The following is a description of a gene set: species: Homo sapiens Human Gene Set: GOBP_DEFENSE_RESPONSE_TO_SYMBIONT Reactions triggered in response to the presence of a symbiont that act to protect or prevent damage to the host., and this is the list of marker genes: TAX1BP1, CD274, NLRX1, TRAF2, GRN, MIF, WFDC10A, DAO, DMBT1, C3, CCDC92, DEFB103A, PRDM1 (PR/SET domain 1), DAB2IP, TRIM43B, SRPK2, BPIFB3, RNASE3, UFD1, TRIM32 (NCBI Gene Id 3971), TNFAIP8L2, TRIM49C, PRKDC, LTF, REG1B, PRSS3, RNF166, PIK3R6, SYK, PSTPIP1, PTPN11, RSAD2, TRIM26, RAET1E, DHX16, RPL13A, DDX60, DEFB118, SIGLEC10, XIAP, TMEFF1, CCL28, APPL2, TRIM68, LRRC19, HSP90AA1 (NCBI Gene Id 89272), CARD8, IFIT3, KIR2DL4, MICA, TUBB, MNDA, CYP27B1, JAK2, KLRG1, IFNA4, CLPB, DHX58 (NCBI Gene Id 79132), SUSD4, IFNA1, IRAK1, CLNK, UMOD, CYBA, VAMP4, PARP9, CCL5, DDX21, NCR1, APPL1, CFD, USP14, CCL17, NFKBIA, HSPA1A, PYDC5, DAPK3, CFB, CD84, GCH1, CCL16, ZDHHC1, ENDOD1, PAK1, MMP12, CNPY3, DHX9, TASL, GBP3, SMIM30, HRG, HDAC6, TRDV2, CXCL6, S100A14, WRNIP1, TARM1, CD74 (NCBI Gene Id 972), CLEC4E, GP2, MSRB1, HAMP, USP38 (ubiquitin specific peptidase 38), KRT16, IFNA2, FGB, C7, PCYOX1L, TLR4, KLRC4, MMP7, EP300, ACTG1, APOL1, LY86, RNF125 (NCBI Gene Id 54941), UBE2L6, PLPP6, IRF5, KIF5B, DEFA3, MAPK8, DEFB107A, SKP2, DEFA1B, ITGAM, IFI35, MRC1, TRIM43, IL12RB1, POLR3C, CAMP, GDI1, CALCOCO2, DEFB125, ELANE, EPRS1, PPP2R3C, TRAF3IP3, KLK7, DEFB128, TRIM63, CEACAM1, S100A7, ZDHHC11B, F2 (coagulation factor II), PLA2G5, SLAMF1, RELB, KLRC4-KLRK1, H2BC12, DEFB134 (defensin beta 134), PIK3CB, TRIM38, SETD2, GZMM, IFNA10, RNF115, CCL25, IRAK2, HERC5, CCL2, CX3CR1, PADI4, PYHIN1, RFPL2, SAMHD1, BPIFB1, CPTP, IKBKG, C1QB (complement C1q B chain), IFNA7, IKBKE, H2BC11, ARHGEF2, SEC14L1, HAVCR2, CCDC134, TRIM15, RIPK2, CD180, C6, EREG, RDUR, PUM2, CCL23, MUL1, HSP90B1, ANKHD1, DEFB1, AP3B1, NECTIN2, RIGI, HDAC4, MARCHF5, STAT1, TRDV3, IKBKB, TRIM11, ATAD3A, LY96, PTX3 (pentraxin 3), ZNF683, PRTN3, IFNA14, CCL27, IFIT1, DHX33, CHUK, SERINC3, PLD4, LYST, GBP1, YTHDF2 (YTH N6-methyladenosine RNA binding protein F2), POLR3B, TRIM48, GATA6, SERPINB9, POLR3F, LACC1, APOBEC3H, YWHAE, GZMB, ESR1, ELP6, N4BP3, RNF170, MPEG1, SRC, MIR520E, SLAMF7, LCN2, IL34, LRRC14, MIR19A, RARRES2, CCL3L3, KLRC3, CAMK2A, PTPRS, BIRC2, NLRP10, TRAFD1, BRCC3 (BRCA1/BRCA2-containing complex subunit 3), PTPN2, LYAR, XRCC6, VIP, IL36B, TRGV2, IL1RL2, CLDN2, TRIM59, C9, BCL3, LRP8, SPINK5, TRIM39, MX1, TRIM77, C8B, TREML1, FPR2, CREBBP (NCBI Gene Id 1387), CIITA, APOBEC3D, OAS1, EDN1, RAB20, GPER1, CCL18, IGHG3, DEFB113, ARL8B, NMI, PTPN6, TOMM70, RB1CC1, CD47, TRIM61, TRAF4 (TNF receptor associated factor 4), AP1G1, NFKBIZ, MX2, CX3CL1, PRKRA (protein activator of interferon induced protein kinase EIF2AK2), OAS3, C4BPB, DCST1, ZDHHC11, LAG3, TARBP2, HCFC2, CLU, LILRA4, TNIP3 (TNFAIP3 interacting protein 3), ZG16, OTULIN, IFNAR1, KIR3DL1, ITCH, CSF1, NR1H2, MORC3, TLR3, HLA-G, MIR149, PDE12, TRIM64C, DEFB106A, IFNA16 (NCBI Gene Id 3449), DNAJA3, IFNK, RPS6KA3, HK1, SLC26A6, MALT1, CR1, CCL14, MAP2K6, C5, VPS26B, RFPL4AL1, NQO1, P2RX7, AKT1, PHB2, LYN, IL33, HLA-E, TAB1, TRIM73, CD209, TMEM45B, ZDHHC18, SH2D1B, ZNRF4, ATG5, RBM14, KCNJ8, UAP1, IL27, MED1, TNFRSF14, NLRP6, POLR3K, CLEC2A, TRIM72, IGHG1, IL12A, HPX, CFP, CCL15, TRIM17, KIR2DS2, CD1D, PPT1, TRIM65, PIK3CD, STMP1, NEK7, IL23R, MIR146A, KYNU, TRIM54, INAVA, C4A, SEMG2, AIF1, ADAR, LYPLAL1, CACTIN, KRT6A, RFPL3, TRIM74, KLK5, IL1RAP, NCF1, ZYX, SAMD9, CLEC4D, HSPD1, PHB1, BPIFA1, RPSA, TMEM43, UBL7, LSM14A, NKG7, F12, CASP8, SHFL, IFNL3, CDC42, CFHR2, RNASE7, MYD88, PYDC2, IRF8 (NCBI Gene Id 3394), IFNGR2, RAB7B, USP44, CORO1A, IL17F, USP29, LY6E, IL23A, CFHR5, DEFB116, SIRT2, A2M, SFN, STAT5A, B2M, MATR3, USP27X, IGHA1, CCL4L2, WFDC13, COLEC10, IFIH1, S100A8, NUB1, TYROBP, FBXL2, CNOT7, CD36, YTHDF3, IL10RB, TMEM33, CFHR1, PTPN1, IGHD (immunoglobulin heavy constant delta), CXCL10, INPP5D, GSDMB, HTN1, GPR146, PPP6C (protein phosphatase 6 catalytic subunit), TNFAIP3, SHMT2, DDX3X, DUS2, IFNA8 (NCBI Gene Id 95818), TRIM51G, NINJ1, ATP1B1 (ATPase Na+/K+ transporting subunit beta 1), CRP, CYLD, CCL4, ULBP3, SMPD1, IRAK3, CD244, TRIM35, HEXIM1, TRIM13, IL17A, RNASET2, TRIM6, PIK3CG, DDX39A, ZNF697, TRIML1, TREML4, NR1H4, MIR21, LETMD1, TRIM31, MIR210, TRIM55, SERINC5 (serine incorporator 5), NLRP1 (NCBI Gene Id 82286), PPP1R14B, SPI1, PF4, RNF19B, CYBB, PARP14, GBP4 (NCBI Gene Id 115361), SNX3, HMGB1, IFNL2, NLRC4, LRRC15, EVPL, OTOP1, ULBP2, SYNCRIP, IRF3, TOLLIP, ZBP1, PRKD1, CCL21, GSDMD, TREM1, USP18, HCST, H2BC6, DEFB4A, ATAT1, IRF4, NMBR, OPTN, SEMG1, CLEC4M, TICAM2, COLEC11, WFDC9, C4B (NCBI Gene Id 721), TRIM23, ANXA1, POLR3G, IGKV3-20, TICAM1, ERAP1 (NCBI Gene Id 51752), GFI1, SP100, CCL1 (NCBI Gene Id 6346), CD300LF, ACTR2, AKIRIN2, KAT5, ANG, TRIML2, PYDC1, TLR1, VIM, YWHAZ, PLA2G2F, CXCL13, RAB43, EIF2AK2, GALP, MID2, H2BC4, PGLYRP4, KLRC1, CDC42EP2, RBM47, DDX41, NCK1, APOBEC3F, JAK3, FCGR2B, ADGRB1, TRIM21, CCL20, CD300A, CD300H, TRIM52, NEURL3, UNC13D, CRTAM, TRIM40, CCL8, CHID1, RNASE4, IFNA17, SCNN1B, LILRA2, SEC61A1, G3BP2, SDHAF4, ZCCHC3, TIFAB, CLEC5A, BTK, C4BPA, TIRAP (TIR domain containing adaptor protein), CST9L, CR2, AQP4, MIR758, ADAM15, AURKB, PSPC1, CALM1, IL21, LGALS3, PUM1, DAPK1, POLR3E, TLR5, NLRC5, SLC15A4, KRT1, ATG14, KLRF1, NPPB, NCR3, SNCA, CXCL14, HLA-DPA1, MST1R, MASP1, DEFB126, CLEC7A, TLR2, SH2D1A, DCD, SIN3A, UBE2K, HMGN2, NMB, SFPQ, TRIM25 (NCBI Gene Id 7706), CXCL11, NLRP9, USP50, FCN3, RFPL4B, GPR108, NLRP2, PCBP2, CCL3, GPS2, DEFB115, SCARA3, APOBEC3C, MARCO, CLEC4C, DEFB108A, METTL3, TLR8, TRIM64B, CEBPG, RNF39 (ring finger protein 39), POLR3H, TIFA, NRROS, PAK2, PLA2G6, PQBP1, IL36A, TRIM8, LAMP2, DHX15, MIRLET7B, DEFB107B, MFHAS1, MAP3K5, STX4, USP17L2, IRGM, APOBEC3B, USP20, STXBP3, RAF1, NFKBIL1 (NFKB inhibitor like 1), FADD, KCNK6, IL17RA, ADAM8, TMEM126A, SLC19A1, DTX3L, LAMP1, JCHAIN, TREM2, WFDC10B, CAV1, SPON2, DEFB108B, CRCP, PGLYRP1, FGR, MIR4691, ATG9A, SERPINB4, CCL22, CDC42EP4, FLOT1, C1QBP, USP15, NPLOC4, STING1, TMEM106A, MCOLN2, SFTPD, ZNFX1, TRIM34, VSIG4, TUBB4B, NLRP2B, SPIRE1, TRIM49D1, ZDHHC3, TKFC, NOD2, TYK2, NOS2, BPIFC, SARM1, LEAP2 (NCBI Gene Id 116842), SLC46A2, SPSB3 (splA/ryanodine receptor domain and SOCS box containing 3), CD96, CALHM6, RAET1G, APP, AIM2, CSNK1A1, WFDC12, OASL, PLSCR1, CXCL3, TRIM49B, HSPA8, IFNE (interferon epsilon), PRSS2, FOSL1, DEFB127, TRIM60, LYZ, TRIM22, APOE, PPARG, ABHD17A, GBP2, EPG5, RNF185 (ring finger protein 185), POLR3D, ECSIT, IFNW1, TRDV1, RFTN1, TBKBP1, NEDD4, NCF2, SPAG11B, WNT5A, SLC15A2, TRIM49D2 (NCBI Gene Id 729384), CD177, GRB2, CXCL1, MMP3, C1S, TOR2A, CRK, SMPDL3B, PI3, CXCL8, DEFB135, WASHC4, HLA-F, DEFB132, TRAF3, IFITM1, TRGV5, HMGB3, XCL2, VAMP3, GBP5, TRIM27, NR1D1, TNIP1, TRIM10, GAPDH, LGR4, CRISP3, FAM3A, MAVS, PYCARD, CD2 (CD2 molecule), FLNB, NOD1, IRF7, CXCL9, CD300E, APOBEC3G, H2BC7, TXK, ARG2, ANKRD17, UBE2W, CD6, AKAP1, PLEKHM2, CXCL16, PRDX1 (peroxiredoxin 1), BPI, CCL19, OTUD4, PIM1, IFNGR1, VAMP2, H2BC10, G3BP1, ISG15, NR1H3 (NCBI Gene Id 113429), UNC93B1, ATG12, PAK3, GIGYF2, SLC15A3, REG1A, RNASE6, BIRC3, SSC5D (scavenger receptor cysteine rich family member with 5 domains), AKAP8, CASP6, BANF1, CGAS, DEFB114, IL36G (interleukin 36 gamma), DEFB130A, CST9LP1, IFNL1, DEFB121, KLRC2 (killer cell lectin like receptor C2), CD55, TANK, SIRPA, TGFB1, C1RL, HMGB2, SLC30A8, TLR7, GKN2, AXL, DEFB105B, IFI16, SPRR2A, CLEC12B, ACOD1, MARCHF2, IGHG4, NAGK, COLEC12, IFIT2, FBXO9, MIR17, APOBEC3A, PIK3R1, DEFA4, UBE2N (NCBI Gene Id 7334), TLR10, MR1 (major histocompatibility complex, class I-related), STXBP4 (syntaxin binding protein 4), KNG1, ZC3HAV1, CDC37, MIR708, CH25H, CLDN1, NAIP, IL18, LILRA5, ROMO1, LEP, PDPK1, NOP53, TRIM41, N4BP1, TRIM62, REL, C1QC, FYN, OAS2, CFI, DEFA6, TF, CST9, TRAF6, KLRD1, TRIM64, XCL1, REG3G, IL36RN, H2BC8, ULBP1, ZDHHC12, ABHD8, IFI27, SQSTM1, IFNA21, BCL10, TUSC2, NTS, C8G, MAP4K2, XRCC5, IFNAR2, STAT2, TRIM14, VAMP7, GARIN5A (NCBI Gene Id 112703), LGALS4, PF4V1, TBK1 (TANK binding kinase 1), LBP, PELI1, CCL26, TMEM120A (transmembrane protein 120A), IGHE, PVR, PJA2, HLA-A, SCIMP, SMARCA5, MYO1C, IRF1, CFH, TLR9, STXBP1, TRIM7, NFE2L2, KLRF2, RPL39, GRAMD4, TRGV9, CADM1, MIR20A, CARD9, MBL2, RNF34, TFEB, TRIM69, TRIM50, DHX36, CEP63, LATS2, IFIT5, S100A9 (NCBI Gene Id 6280), SMPDL3A, LGALS9, HVCN1, INS, RASGRP1, FCN2, MAP3K7, APCS, UBD, C1R, PTPN22, TRIM29, NAGLU, RTN4, CD160, LCN10, WFDC5, NLRP3, FCGR3A, ISG20, ARG1, IRAK4, ALPK1, NPY, FLOT2, CCL13, ADM, DDX1, GATA3, LATS1, CPT1A, CTSS, KLRB1, ZDHHC9, TRIM56, CD40, DEFA5, TREX1, TP53, ZDHHC5, DEFB106B, DEFA1, TAC1, SLAMF6, C8A, PGLYRP3 (NCBI Gene Id 114771), ZBTB1, DEFB110, CD14, DEFB119, FOSL2, DEFB104B, IPO5 (importin 5), PGLYRP2, CCL24 (C-C motif chemokine ligand 24), CRIPTO, ZDHHC4 (NCBI Gene Id 55146), RPS19, CCL7, IFITM2, FAU, CD300C, RAB27A, WDFY1, AZU1, NLRC3, IFNB1, DEFB131A, IFNA5, DEFB105A, TSPAN6, IL12B, NECTIN4, MIR520B, C1QA, MARK4, STXBP2, TRIM4, VNN1, TSLP, PGC, SLC11A1, BECN1, TLR6, KCNK13, IFNLR1, LY9, MASP2, TRIM75, CXCL12, RNASE8, TRGV4, BSPRY, PML, TRGV8, UBQLN1, TNF, LILRB1, HTN3 (NCBI Gene Id 3347), ZNRF1, DEFB112, KLK3, RPL30, IPO7, FGA, CASP1, DEFB124, RNASE2, EIF4E2, DEFB123, FCAR (Fc alpha receptor), CHGA, UBA7, POLR3A, F2RL1, CLEC10A, MIR181B1, NLRP4, PELI3, CALCA, TNIP2, CD46, PPBP, GNLY, BST2, SLC22A5, TRIL, JAK1 (NCBI Gene Id 3716), MAPKAPK2, RELA, TRIM3, SLAMF8 (SLAM family member 8), IGHA2, FCN1 (ficolin 1), MAPKAPK3, TTLL12 (NCBI Gene Id 23170), PRKCE, TRIM49, ACTR3, TRGV3, PLA2G1B, IFNA6, SLPI, IFNG (interferon gamma), IGHG2, TRIM51, PPP2CA, DEFB136, TMED1, GSN, CASP4, WFDC2, IGHM, DEFB104A, CLEC4A, RAB2B, ARID5A, TTC4, RFPL4A (NCBI Gene Id 649055), TRIM58, ILRUN, CXCL2, CTSG, CLEC6A, STX8, MIR200B, CYBC1, DEFB131B, KLRK1, LRCH4 (leucine rich repeats and calponin homology domain containing 4), RFPL1, FASLG, APOA4, SENP7, DTX4, NFKB1, CD200, WAS, H2BC21, S100A12, HLA-B, PLCG2, VAV1, ADARB1, CD58, RNF135, GBP6, PIK3AP1, ADAMTS13, ARRB2, STAT5B, FCGR1A, DEFB133, IFITM3, CITED1, AARS2, CD226, RIOK3, RNF144A, MIR140, C2, PARP1, TIGIT, AZI2, NONO, TRIM5, IFNL4, HSPA1B, CSF1R, FFAR2, MIR200C, IFI6, SERPING1, POMC, MUC7, OGT, RAB11FIP2, GPATCH3, TYRO3, DRD2, FCER1G, WFDC11, ASS1, REG3A, DUSP10, TRIM28, RASGRP4, FCRL3, GBP7, HCK, H2BC12L, ERBIN (erbb2 interacting protein), WFDC3, CCL11, MEFV, DEFB103B, RPS6KB1, IL18RAP, SRPK1, TRIM44, CXCL5, HLA-C